The following is a description of a gene set: Human Gene Set: HP_OSTEOLYTIC_DEFECTS_OF_THE_DISTAL_PHALANGES_OF_THE_HAND species: Homo sapiens Osteolytic defects of the distal phalanges of the hand, and this is the list of marker genes: ZMPSTE24, CTSK, LMNA, PDGFRB, BANF1